The following is a description of a gene set: studied in species Homo sapiens Any apoptotic process in a dendritic cell, a cell of hematopoietic origin, typically resident in particular tissues, specialized in the uptake, processing, and transport of antigens to lymph nodes for the purpose of stimulating an immune response via T cell activation. Human Gene Set: GOBP_DENDRITIC_CELL_APOPTOTIC_PROCESS, and this is the list of marker genes: BCL2, CCL19, AXL, CCR7, CCL21, LYN, LGALS9, CXCL12, NR4A3, BCL2L1, RAPGEF2, GAS6, LILRB1